The following is a description of a gene set: species: Mus musculus Mouse Gene Set: GOBP_ASTROCYTE_DEVELOPMENT The process aimed at the progression of an astrocyte over time, from initial commitment of the cell to a specific fate, to the fully functional differentiated cell. An astrocyte is the most abundant type of glial cell. Astrocytes provide support for neurons and regulate the environment in which they function., and this is the list of marker genes: Egfr, Cntf (ciliary neurotrophic factor), Nf1, Trem2, C5ar1, Tspan2, Psen1 (NCBI Gene Id 19164), Eif2b5, Ror1, Drd1, Dll1, Ror2, Lamc3, S100a9 (NCBI Gene Id 99917), Grn (granulin), Ifngr1, Smo, Kras, Zeb2, Adora2a, Vim, C1qa, Il1b, Gfap, Lrp1, Naglu, Csf1r, Ager, S100a8, Nr1d1, Gm5849, Pou3f2 (POU domain, class 3, transcription factor 2), Lamb2, Ldlr, App, Plp1, Tlr4, Ifng, Agt